Given this list of marker genes SOX4, NKX2-5, TP53, VANGL2, SLIT3, APLNR, CHD7, MDM2, GJA5, FZD1, BMPR2, HEY2, RARA, ADAMTS19, TBX3, ROBO1, SMAD6, TBX20, ENG, ZFPM2, NOG, RBM15, BMP5, GATA6, MIR17HG, RARB, TBX5 (T-box transcription factor 5), DNAH11, MKS1, NRP2, ISL1, TGFB2, SMAD4, JAG1, HEY1, PARVA, NSD2, SMAD7, CCN1, SMO, FGFR2, HEYL, HAND1, ID2 (NCBI Gene Id 3398), EGLN1, TBX1, NRP1, NOTCH2, SEMA3C, BMPR1A, NOS3, MSX2, GATA4, ZFPM1, FZD2, TGFBR2 (NCBI Gene Id 7048), NOTCH1, TGFBR1, RBPJ, MIR1-1, BMP4, TBX2, PITX2, LRP2, SLIT2, ACVR1, DHRS3, PROX1, TGFBR3, BMP7, FGF8, WNT11, SOX11, FGFRL1, ROBO2, SAV1, HES1, CITED2, here is a description of the gene set: studied in species Homo sapiens The process in which the anatomical structure of a cardiac septum is generated and organized. A cardiac septum is a partition that separates parts of the heart. Human Gene Set: GOBP_CARDIAC_SEPTUM_MORPHOGENESIS